The following is a description of a gene set: An organ system process carried out at the level of a muscle. Muscle tissue is composed of contractile cells or fibers. studied in species Homo sapiens Human Gene Set: GOBP_MUSCLE_SYSTEM_PROCESS, and this is the list of marker genes: TMOD2, ANXA6, TIFAB, HMOX1, ATP2B1, BECN1, GLRA1 (glycine receptor alpha 1), CCDC78, STC1, NDUFS6, HTR2B, ACTC1, P2RX4, MKKS, LMOD2, TACR1, MYOG, MIR34C, DCANP1, SULF1, MIR133A1, FOXP1, COMP, PPARG, LEP, MYMK, MIR19B1, PDE4D, GJA5, TRDN, TMOD3, LMNA, SLC6A8, MYH11, CASQ1, RHOA, TNFRSF1B, P2RX1, GNAO1, KCNE1, GALR2, MLIP, SYNM, KCNJ3, EDN3, PIK3CA, ARG2, MIR24-1, ZC3H12A, CACNA1S, GLRX3, MIR499A, MYL6, PRKG1, ATP8A2, CACNB2, NMUR1 (NCBI Gene Id 10316), NR4A3, NKX2-5, INPP5F, GUCY1A1 (NCBI Gene Id 2982), PABPN1, KIT, PIK3CG, FLNA, OXT, PARP2, ABCC9, SNTB1, P2RY1, TTN, ARHGEF11, RGS2, CSRP3, GAA (alpha glucosidase), ADA, TMEM38B, SCN7A (sodium voltage-gated channel alpha subunit 7), CALCA, TCAP, CTTN, ADRA1B, ASB2 (ankyrin repeat and SOCS box containing 2), DRD2, CTDP1, CACNA1G, FGF13, ADORA2B, MYL2, CHRM2, GATM, PTGER3 (prostaglandin E receptor 3), MYL6B (NCBI Gene Id 140465), TNNC2, PAK1, MYOT, TPM2, ITGA2, DRD1, FOXO1, ACACB, MAP2K3, MEIS1, TRIM63, CAMK2D, HEY2, P2RX2, OXTR, CHRNE, LMCD1, SMAD4 (NCBI Gene Id 4089), MIR448, RAP1GDS1, GSTM2, EDNRA, NMU, HTR1D, AGT, TNFRSF1A, JPH3, ADRA2A, MIR145, G6PD, DTNA (NCBI Gene Id 86552), REM1, PDGFB, MTPN, SELENON, RGS4, HSP90AA1, SCN4B, ZDHHC21, TMOD1, CERT1, GSTO1, SLN, GJA1, JPH2, JUP, KCNJ2, CD38, TNNI3, SMAD7, SCN11A, APLNR, EDNRB, SORBS2, YY1, PROK2, SRSF1, MIR30E, CLIC2, EDN1, NOTCH1, KCND2, TBX20, KCNQ1, STRIT1, FOXO3, CHGA, MYH4, MYH7, PDE9A, RNF207, MIR17HG, TOMM70, ASPH, MTOR, CALM2, FXYD1, STAC, TRPM4, MYH14, NEDD4L, NOS1, PPP1R12B, CHRNA1, IL6ST, FKBP1B, CACNG1, CASQ2, ATP1A2, ADORA1, MIR15B, IRAG1, ENO1, IL1R1 (NCBI Gene Id 3554), TNNT2, ACTA1, EMD, RYR2, TRPV1, LTB4R, JPH4, TPM1, UTS2, HDAC4, GHSR, TNNI1, MIR34B, BMP10, TMEM38A, FKRP, SCN9A, CRYAB, MIR17, ROCK1, GSK3A, HAND2, TNNI2, TPCN2, MYL3, NOL3, CLCN1, SSPN, MIR195, PPP3CA, PIK3C2A (phosphatidylinositol-4-phosphate 3-kinase catalytic subunit type 2 alpha), P2RX3, ATP1B1, ACTA2, CACNB1, ROCK2, TPM4, ANK2, CACNA1H, NPPA, ABAT, SGCD, DLG1, MIR21, ANKRD2, MIR25, ADCY10 (NCBI Gene Id 82259), MYOD1, DAG1, BDKRB2, HTR7, SLC8A3, SCN4A, CHRND, COL14A1, GSN, MYLK2, MAP2K1, PLN, ADRA2C, C12orf57, MYOZ2, GPER1, CHRNA3, ALDOA, HCN4 (NCBI Gene Id 10021), COL6A1, C10orf71, ACE2, KCNE2, SRF, MIR328, UTRN, MYH2, VPS54, IGF1, KCNN2, CHRM3, KCNB2, MYL9, SPHK1, F2R, MYOC, MIR214, TRPC3, TRPA1, KLF4, ABCC8, TRIM72, KCNJ12, ATP2A2, NOS1AP, P2RX6, MIR208B, PRKACA, ATP2A1, LARGE1, BBS2 (Bardet-Biedl syndrome 2), PPP1R13L, GRIP2, CAV1, KCNJ8, SCN3B, MYL4, GRK2, MIR199B, MIR19A, DOCK5, MYH13, MYH6, ARRB1, DSP, GATA6, MYL1, TBXA2R, CKMT2, CNN1, SUMO1, MIR143, AKAP9, NOS3, KDM4A, BIN1, MIR20A, UCN, MYL5, TNNT1, ATP1A1, CALM3, SPX, KLF15, PKP2, DSC2, PI16, NUP155, PGAM2, MYBPC3, DDIT3, CHRNB2, GJC1, JSRP1, KCND3, SCN5A, SETD3, GATA4, DAPK3, EEF2, PRKCA, PDGFRB, RANGRF, MYOF, RCSD1, EZH2 (NCBI Gene Id 392834), NPY2R, CACNA1D, GPD1L, APBB1, CALM1, IL1B, TBCE, SRI, DMD, PPARA, STAC3, KCNE5, TBX3, CAV3, JPH1, CERS1, NMUR2, KBTBD13, SCN2B, KCNA5, SULF2, ADRA1A, TACR2, GAMT, DOCK4, MIR23A, PDLIM5 (PDZ and LIM domain 5), GDNF, PRKAG3, SMPX, TNNT3, MYBPH, GTF2IRD1, NPNT, FGF12, ORMDL3, ERRFI1, PARP1, ATP2B4, SCN10A, SCN2A, APBB2, HTR2A, KCNH2, SLC8A1, MAP2K6, CACNA2D1, TNF, MIR200C, GHRL, SCN1A, FKBP1A, TNNI3K, KCNE4, MIR153-1, KCNJ5, SGCA, ADRB2, MYH1, SNTA1, MYL11, TNNC1, HRC, CAMTA2, SMTN, ACTN3, RYR1, CAMK2G, RYR3, MSTN, MYOCD, MYH3, TMOD4, ARHGAP42, MYH8, KCNMA1, MIR208A, DES, SCN3A, CHRNB1, EHD3, ADRA2B, DMPK, AKAP6, CFLAR, TPM3, VEGFB, HSBP1, MIR199A1, STAC2, KCNA1 (NCBI Gene Id 729214), MYH7B, SMAD3, PRKD1, CHRNG, PVALEF, CTNNA3, IGFBP5, EDN2, SOD1, SCN1B, MEF2A, KLHL41, STUB1, TACR3, MYOZ1, KCNE3, DSG2, FBXO32, CHRNB4, HDAC2, CACNA1C, ARRB2, SCN8A, LMOD1, MYOM2, MYLK, PAK2 (p21 (RAC1) activated kinase 2), NEUROG1, CHUK, CYBA, SLMAP, ADGRD1, MIR1-1, SCNN1B, PDE4B, CAMK2B, KCNIP1, CALD1, KCNIP2, TRPV4 (NCBI Gene Id 8098), TWF1, LMOD3, SCO2, HOMER1, SMAD5, GATA5, TBX2, SLC9A1